The following is a description of a gene set: from publication Lund R, Aittokallio T, Nevalainen O, Lahesmaa R (PMID 14607935) species: Homo sapiens Th1 and Th2 cells arise from a common precursor cell in response to triggering through the TCR and cytokine receptors for IL-12 or IL-4. This leads to activation of complex signaling pathways, which are not known in detail. Disturbances in the balance between type 1 and type 2 responses can lead to certain immune-mediated diseases. Thus, it is important to understand how Th1 and Th2 cells are generated. To clarify the mechanisms as to how IL-12 and IL-4 induce Th1 and Th2 differentiation and how TGF-beta can inhibit this process, we have used oligonucleotide arrays to examine the early polarization of Th1 and Th2 cells in the presence and absence of TGF-beta after 0, 2, 6 and 48 hours of polarization. Human Gene Set: GSE2770_IL12_AND_TGFB_ACT_VS_ACT_CD4_TCELL_48H_DN Genes down-regulated in CD4 T cells activated by anti-CD3 and anti-CD28: TGFB1 and IL-12 (48h) versus untreated (48h)., and this is the list of marker genes: CHADL, AP3M1, ELL2, MIOS, HUS1, ARMC8, ALG2, DDX41, KPNA4, BTBD6, GTF2I, NUP107, IPPK, HELLS, OLR1, CAMKK2, FHIP2B, PRSS41, CPSF4, OTUD6B, PRPF40A, ARL8B, PSMD11, WDHD1, RNF217, CDC73, PPIP5K2, NSMAF, PUS1, GRWD1, DNMT3B, C22orf23, CBLN2, RRS1, HSPD1, MRPS2 (mitochondrial ribosomal protein S2), ZNF644, METAP2, FTSJ3, RNF168, ALDH3A2, DCTD, PITPNA, UNC79, FAM210A, GTPBP4, CHUK, GARS1, BTG3, ACVRL1, GJA1, PDAP1 (PDGFA associated protein 1), PSPC1, GALC, HDAC2, DKC1, INTS14, YY1, TM9SF2, GAR1, RBM28, FAM98A, KCTD3, FAAP24, KRTDAP, CTPS1, ABHD13, SEMA4F, JAG1, LIN54, DDIAS, NOB1, ITGA8, MORF4L1, ALKBH4, KNL1, SLC35B4, KCNQ5, IK, ATP6V1E1, YOD1, CDCA4, RAP2C, LY6E (lymphocyte antigen 6 family member E), H2AX, DIO2, SEC61A1, NAF1, CAMP, SPTLC1, BOP1, GNL3, SHMT1, METTL16, CDT1, MOGS, KTI12, TOPBP1, SLFN12, KPNB1, QTRT2, HOOK1, SAE1, API5, UBE2J2, MYL10, SMARCAD1, GSDMC, USP46, NOP58, NQO1, ATIC, HSPA9, SEC23B (NCBI Gene Id 980), ENPP4, REPS1, CCDC14, MORF4L2, NOP9, B3GALNT2, HIRIP3, HSPH1, NDC1, HNRNPH2, TWF1, GMPS, ZDHHC6, DDX27, TLCD3A, SRSF1, SOCS6, GPRASP3, SRM, ATAD3A, METAP1, EXO1, POMT1, CDKN2AIP, SETDB2, PBX4, MTF2 (metal response element binding transcription factor 2), HIF1A, CTU1, FAM185A, TARDBP, CRLF2, KLF12, ACSL4, NFXL1 (NCBI Gene Id 246220, nuclear transcription factor, X-box binding like 1), CENPV, KDM2B (NCBI Gene Id 84678), CARD10, FASTKD3, ERI3, PXYLP1, DBF4, RSBN1, ROPN1L, ISG20L2, BLM, TMEM39A, DHRS11, NUP160, SUV39H2, CPSF6, TPX2, PA2G4 (NCBI Gene Id 5036), NUS1, NT5E, SFXN2, KBTBD8, M6PR, DDX1, CEP162, PROK2, ANP32B, RBM39, CITED4, RAD21, LIMD2, HBS1L, SAMD9L, SUV39H1, RANBP6, ZNF146, ASPRV1, SSR3, JPT2, THUMPD1, ALOX5AP, ZNF546 (NCBI Gene Id 7600), FAM91A1, SERBP1 (NCBI Gene Id 51624), CLPTM1L, RAB34, UBA6, NRBP1, ATXN7L3B, CEP170B, RAE1